Given this list of marker genes Zwint, Piwil2 (NCBI Gene Id 57746), Dmrt1, Prdm9 (PR domain containing 9), Fbxo5, Eif4g3, Psma8, Knl1, Wee2, here is a description of the gene set: studied in species Mus musculus Mouse Gene Set: GOBP_REGULATION_OF_MEIOSIS_I Any process that modulates the rate, frequency, or extent of meiosis I, a cell cycle process comprising the steps by which a cell progresses through the first phase of meiosis, in which cells divide and homologous chromosomes are paired and segregated from each other, producing two daughter cells.